The following is a description of a gene set: from publication Seitz S, Frege R, Jacobsen A, Weimer J, Arnold W, von Haefen C, Niederacher D, Schmutzler R, Arnold N, Scherneck S (PMID 15580292) Genes down-regulated in CT60/4 cells (breast cancer reverted to normal by transfer of chromosome 8p region) vs parental MDA-MB-231 cells (deleted chromosome 8p). Several investigations have supposed that tumor suppressor genes might be located on human chromosome 8. We used microcell-mediated transfer of chromosome 8 into MDA-MB-231 breast cancer cells and generated independent hybrids with strongly reduced tumorigenic potential. Loss of the transferred chromosome results in reappearance of the malignant phenotype. Expression analysis identified a set of genes (CT8-ps) differentially expressed in microcell hybrids as compared to the tumorigenic MDA-MB-231 and rerevertant cells. Of these, 44.9% are differentially expressed in human breast tumors. The expression pattern of CT8-ps was associated with prognostic factors such as tumor size and grading as well as loss of heterozygosity at the short arm of chromosome 8. We identified CT8-ps networks suggesting that these genes act cooperatively to cause reversion of tumorigenicity in MDA-MB-231 cells. Our findings provide a conceptual basis and experimental system to identify and evaluate genes and gene networks involved in the development and/or progression of breast cancer. species: Homo sapiens Human Gene Set: SEITZ_NEOPLASTIC_TRANSFORMATION_BY_8P_DELETION_DN, and this is the list of marker genes: CLIP2, TGFA, CXCR4 (NCBI Gene Id 93405), PHF20, LIMCH1, PXDN, DDIT4, MMP1, SCG5, UBXN7, SAA1, INSIG1, IL11, PSPH, IL1A, L1CAM, CST6, FKBP9, PIK3CD, SLC2A10, RCN2 (NCBI Gene Id 5955), QPCT (NCBI Gene Id 25797), CDKN1A, CDH4, FKBP11, SLC19A2, HERC2P9, PHF1, COL8A1, GAD1, UQCRC1, CSF3